The following is a description of a gene set: The process whose specific outcome is the progression of the nose over time, from its formation to the mature structure. The nose is the specialized structure of the face that serves as the organ of the sense of smell and as part of the respiratory system. Includes the nasi externus (external nose) and cavitas nasi (nasal cavity). studied in species Homo sapiens Human Gene Set: GOBP_NOSE_DEVELOPMENT, and this is the list of marker genes: PROX1, MSX1, CHD7, SKI, SIX4, SMCHD1, HESX1, SIX1, DLX5, GNG8, ASCL1, GLI3, RPGRIP1L, STRA6, ALDH1A3, RDH10